The following is a description of a gene set: species: Homo sapiens Human Gene Set: GOBP_NEGATIVE_REGULATION_OF_NUCLEOTIDE_CATABOLIC_PROCESS Any process that stops, prevents, or reduces the frequency, rate or extent of the chemical reactions and pathways resulting in the breakdown of nucleotides., and this is the list of marker genes: MTCH2, PPP2CA, STAT3, NUPR1, CBFA2T3, GIT1, ACTN3, HDAC4, TIGAR, DDIT4, TRIM63, PPARA, SIRT6, FBP1, FLCN, SLC4A1, NCOR1, PRKACA, PFKFB1, IER3